The following is a description of a gene set: Mouse Gene Set: GOBP_B_CELL_PROLIFERATION_INVOLVED_IN_IMMUNE_RESPONSE The expansion of a B cell population by cell division following B cell activation during an immune response. studied in species Mus musculus, and this is the list of marker genes: Plcl2, Cd19, Gapt, Cd180, Abl1, Tlr4